Given this list of marker genes MAP4K4, ZMYM4, JMJD1C, DLG3, IL27RA, WDR46, CA2, CREBL2, MGP, ARL4C, HBP1, CTSS, ZNF507, ATE1, JMY, TOP2B, RPLP1, ACSL3, ERBIN, ATXN3, HECTD2, CCDC126, KLF13, AMER1, SRRM2, NSG2, CRYBA1, RPS14, NFRKB, SELENOW, PSD, TBCEL, PNRC1, ZMYM2, ARHGAP35, SLC25A27, PACC1, KMT2C, SEMA4F, ABCG1, NUCB2, TWNK, YAE1, SPRED2, FOXO1, RPS18, RAB6B, CERS6, RPS29, FAM86B2, KPNA4, FLCN, KBTBD11, ELK4, EEF2K, RNF167, DYRK2, RELCH, NR2C1, CLIP1, NCKAP5L, BRDT, LEMD3, TCF20, WDR41, LDLRAD4, SUCO (NCBI Gene Id 51430), THADA, DBP, CNR2, RUNDC3B, UTRN, TRIM56, ADGRL1, ALG1, IRF6, SNN, RPS5, KLK8, PDZD9, IER5, RPLP2, ZMAT1, TESC, DDIT3, RDH13, SNHG12, RAPGEF6, ART4, C19orf38, TCF12, SENP6, JADE2, PBXIP1 (PBX homeobox interacting protein 1), TMCC1, KMT2E, ARHGEF11, SPIN1, ZRANB1, RNF24, CARD6, RAPGEF2, WASL, ZBTB11-AS1, ZBTB20, ZBTB39, NCOA2, R3HDM1, PHF23, SNHG8, ZNF667, SERAC1, ABI3, TRIO, EGR3 (NCBI Gene Id 1960), NFIX, THRA, TTC3, RCL1, CTNS, PJA2, KLF7, TCEANC2, GPR146, RPS8, PHPT1, CCDC73, CAMSAP2, ZNF467, CHST15, ARRDC3, ITM2A, RERE, SALL2, EPM2AIP1, TMEM87B, CLMP, LIPA, DDX50, MINDY2, RASA2, SMIM14, PATJ (PATJ crumbs cell polarity complex component), FILIP1L, MGST2, RPL5, MPPE1, RBM5, COL11A2, CDKN1B, SH3BP5, BCOR, FAM8A1, ZNF354C, NIPSNAP2, TXNRD3 (NCBI Gene Id 93415), RPL38, ZBTB18, PRPF40B, ADGB, MCFD2, GATAD2B, ESCO1, CFL2, ZDHHC17, HIVEP2, USP32, QTRT1, PRF1, NEXN, IQSEC1, TMEM63A, ATN1, BTG2, SSBP2, SESN3, PHF14 (NCBI Gene Id 9678), TMEM185A, SKIL, ZFP28, ZFP36L2, ADNP, MGAT5, PDE4B, PPP2R5A, ST8SIA1, NR1D2, CD302, RAB3IP, CCNT1, ZFP1, GPR18, ZNF471, LINC00511, ZNRF1, JMJD8, DCAF11, SULF2, EIF4B, P2RX4, here is a description of the gene set: T follicular helper (Tfh) cells play a pivotal role in germinal center reactions, which requires Bcl6 transcription factor. To analyze their relationships with other effector T cell lineages and their stability in vivo, we developed and analyzed a new Bcl6 reporter mouse alone or together with other lineage reporter systems. Assisted with genome-wide transcriptome analysis, we show substantial plasticity of T cell differentiation in the early phase of immune response. At this stage, CXCR5 appears to be expressed in a Bcl6-independent manner. Once Bcl6 is highly expressed, Tfh cells can persist in vivo and some of them develop into memory cells. Together, our results indicate Bcl6 as a bona fide marker for Tfh polarized program. Human Gene Set: GSE40068_BCL6_POS_VS_NEG_CXCR5_POS_TFH_DN Genes down-regulated in CXCR5+ BCL6+ follicular helper T cells versus CXCR5+ BCL6- CD4+ T cells. studied in species Homo sapiens from publication Liu X, Yan X, Zhong B, Nurieva RI, Wang A, Wang X, Martin-Orozco N, Wang Y, Chang SH, Esplugues E, Flavell RA, Tian Q, Dong C (PMID 22987803)